The following is a description of a gene set: Genes up-regulated in post-GC, BCL6 dependent B cell non-Hodgkin's lymphoma (B-NHL) vs MYC driven pre-GC lymphoma. Mouse Gene Set: PASQUALUCCI_LYMPHOMA_BY_GC_STAGE_UP from publication Pasqualucci L, Bhagat G, Jankovic M, Compagno M, Smith P, Muramatsu M, Honjo T, Morse HC 3rd, Nussenzweig MC, Dalla-Favera R (PMID 18066064) studied in species Mus musculus Most human B cell non-Hodgkin's lymphomas (B-NHLs) derive from germinal centers (GCs), the structure in which B cells undergo somatic hypermutation (SHM) and class switch recombination (CSR) before being selected for high-affinity antibody production. The pathogenesis of B-NHL is associated with distinct genetic lesions, including chromosomal translocations and aberrant SHM, which arise from mistakes occurring during CSR and SHM. A direct link between these DNA remodeling events and GC lymphoma development, however, has not been demonstrated. Here we have crossed three mouse models of B cell lymphoma driven by oncogenes (Myc, Bcl6 and Myc/Bcl6; refs. 5,6) with mice lacking activation-induced cytidine deaminase (AID), the enzyme required for both CSR and SHM. We show that AID deficiency prevents Bcl6-dependent, GC-derived B-NHL, but has no impact on Myc-driven, pre-GC lymphomas. Accordingly, abrogation of AID is associated with the disappearance of CSR- and SHM-mediated structural alterations. These results show that AID is required for GC-derived lymphomagenesis, supporting the notion that errors in AID-mediated antigen-receptor gene modification processes are principal contributors to the pathogenesis of human B-NHL., and this is the list of marker genes: Pex11a, Mt1, Bbs7, Rbm47, Spcs1, Cdc42bpb, Snai2, Clptm1l, Bbs2, Hipk1, Edem2, Dll3, Skil, Rab20, Spats2, Malat1, Slc7a5, Pawr, Eya4, Amz2 (archaelysin family metallopeptidase 2), Txndc11 (NCBI Gene Id 76370), Gm32633, Top1mt, Evc2, Gm5547, Surf4, Sel1l, Myom1, Syde2, Wfs1, Derl1, Tanc2, Sec24a, Ifitm3, Phlda1, Piwil4, Fbxo17, Tacc2, Nars1, Enpp1, Pycr1, Nckap1, Nudt4, Lman1, Lars1, Tert, Pon2, Basp1, St14, Nrg2, Ankrd6 (ankyrin repeat domain 6), Farp2, Dclre1b, Fabp5 (NCBI Gene Id 16592), Entpd1, Chid1, Gls2, Tgm2, Cited2, Chrnd, Pdia4, Mboat2, Ssr2, Sec24d, Dusp16, Rabggta, Mt2, Sec61a1, Rrbp1, Syne4, Tmed9, Uck2, Rgs3, Abcc1, Selplg, Foxp2, Edem1, Stt3a, Leprotl1, Sting1, Ssr3, Large2, Gpm6a, Crlf1, Creld2, Ctsz, Xbp1, Etl4, Dcaf12, Tulp3, Hdlbp, Cacna1h, Pecr, Gm13261, Csrnp1, Abca1, Fnip2, Myo1d, Ppef2, Atosa, Fkbp14, Sema4g, Btg3 (BTG anti-proliferation factor 3), Anxa5, Stard5, Slc16a6, Gabra4, Mpzl2, Itgb5, Slc12a8, Cnpy2, Praf2, Nfil3, Mamdc2, Tpst1, Cltb, Pla2g12a, Manf, Igf1r, Tmem150a, Ccn4, Clvs1, Epcam, Tent5c, Slc1a3, Dusp22, Slc25a39, Spcs2, Trpt1, Uaca, Tspan15, Trib1, Nomo1, Cd44, Man1b1, Matn2, Mansc1, Smoc1, Ggta1, Hsp90b1, Wipi1, Sdc3, Faxc, B3galnt1, Rhob, Shroom3, Irf6, Ell2, Fam135a, Intu, Eci2, Kdelr1, Atp2b4, Atp6v0c, Rhobtb1, Srprb (NCBI Gene Id 20818), Prrg4, Kcnn4, H13, Pdia3, Tspan31, Abcb1b, Il6st, Dennd5b, Coq3, Armcx3, Tmed10, Sdc1, Aldh7a1, Unc13b, Ica1, Maged1, Smpdl3b, Trp53inp1, Chst11, Sh3bgrl2 (NCBI Gene Id 68100), Tspan13, Oxr1, Cpeb3, Ada, Tnfrsf17, Gorasp2 (NCBI Gene Id 99405), Negr1, Dusp9, Spint2, AU020206, Mtdh, Fkbp11, Eaf2, Srp68, Yap1, Pdia6, Rexo2, Slc38a10, Rhobtb3, Rhpn2, Pgam2 (phosphoglycerate mutase 2), Cystm1, Ccnd2 (cyclin D2), Rab2a (NCBI Gene Id 93773), Pik3cb, Spag6, Cdk18, Agpat5, Plekhf1, Filip1, Cebpb, Zfp9, Slc46a1, 1700017B05Rik, Gusb, Mcfd2, Armcx2, Tst, Bmp8b, Dynll2, Gstp3, Rrp1b, Prdm1, Rasip1, Ttc13, Fut4, Gpr89, Rab3d, Tjp1, Eppk1, Tg, Srp54a, Rpn1, Cfap251, Cd2bp2, Cers6, Selenom, Ergic1, Ube2j1, Ero1a, Bex3, Asph, Laptm4b, Antxr1, Tmem38b, Fads3, Usp2, Irs2, Fads2, Btg2, Slc25a33, Plpp5, Phlda3, Mgarp, Lax1, Hivep3, Prickle1, P4hb, Yipf6, Dsp, Blnk, Ckap4, Ssr1, Lpin2, Coro2b, Ccng1, Tpst2, Pvr, Nbea, Cacnb3, Echdc2, Irf4, Ppa1 (NCBI Gene Id 67895), Dusp14, Epdr1, Laptm4a, Bhlha15, Spint1, Aig1, Creb3l2, Fndc3b, Hid1, Osbpl1a, Asns, Cdv3, Tmem248, Ccpg1, Hnrnpll, Slamf9, Kdelr2, Extl2, Cped1, Mfsd4a, Tmed1